The following is a description of a gene set: from publication Shinohara H, Behar M, Inoue K, Hiroshima M, Yasuda T, Nagashima T, Kimura S, Sanjo H, Maeda S, Yumoto N, Ki S, Akira S, Sako Y, Hoffmann A, Kurosaki T, Okada-Hatakeyama M (PMID 24833394) Genes down-regulated in B lymphocytes: wildtype versus MAP3K7. species: Homo sapiens Human Gene Set: GSE41176_WT_VS_TAK1_KO_UNSTIM_BCELL_DN The activation signaling of transcription factor nuclear factor-kB (NF-kB) plays central role for immune system. One of key kinase mediating this pathway is TAK1 in adaptive and innate immunity. However, role of TAK1 in B cell receptor signaling is still unclear. To know effects of TAK1-deletion on the gene expression induced by anti-IgM, we performed the time course analysis in comparison of wild type with TAK1-deleted splenic B cells., and this is the list of marker genes: TNS4, SPATA6L, SELP, CFD, HIGD1B, GGT7, TSLP, SPINK4, SLC6A5, ZNF563, MYL3, ADH4, SPOCK1, SAP18, CYP2U1, ARHGAP33, ADGRG3, PPARGC1A, ACKR1, ZCCHC18, TNFRSF19, CLEC4F, TRPM3, JADE2, TNFRSF9, KLHL11, CHCT1, MARF1, ABLIM2, COL9A1, KCTD2, COLEC11, CES5A, ADAM32, ANKRD63 (NCBI Gene Id 100131244), MUC13, NOG, GRIK2 (glutamate ionotropic receptor kainate type subunit 2), CNR1, PLEKHG5 (pleckstrin homology and RhoGEF domain containing G5), SLC38A5, KRT32, DDR1, CRYAA, CCDC25, ANGPTL7, TMEM74, KRTAP21-1, KXD1, CLK1, PDE3A, C22orf23, ATP7B, PRDM16, C16orf95, PEBP1, CGN, MIA, HTR1F, AICDA, CCDC73, OR10J5, THG1L, IL1R1, SOX3, DCAF12L1, PDP2, RBMXL2, ZFC3H1, CEND1, GANC, TTC23, MSX1, GPR3, DNAI2, NIPAL2, MAPK13, PSMB11, GRIK3, RGS12, WIF1, LHCGR, BTN1A1, MFAP1, FLVCR2, RRH, TINAG, SLC26A1 (NCBI Gene Id 10861), NSL1, ZNF239, OTOS, RPL35, FREY1, ADM2, CYP17A1, TMEM213, PLA2G2F, PGR, TNPO3, LYPD2, FAM181A, GP2, SLC22A6, TBX6, CHRNE, SLITRK4, TAS2R1, MACROD2, RERG, EPS15L1, USP49, CORT, C4orf19, H2BC13, PDZK1, C2orf72, GOLT1A, MYMK, PARVA, C5orf47 (NCBI Gene Id 133491), MED12L, PIP, MZB1, COL4A4, KLHL10, HAO1, TENM1, KL (NCBI Gene Id 9365), CHRNB1 (NCBI Gene Id 1140), TIE1, AQP5, CACNA1G (NCBI Gene Id 8913), HLA-DRA (NCBI Gene Id 7930), ATP10B, TUT1, DUS2, MISP, HLA-A, SLC1A2, CELA2A, GLP1R, CES1, DNALI1, SLC35F3, ITIH1, DYNC2H1, SLA2, LRRC20, CLPS, FOXA3, CELSR2, KCNJ16, TMEM121B, EMC1, TOGARAM2, GNE, SVOP, HOXC8, TMOD2, URI1, GP6, SYNE4, PCDHB7, LMNTD2, ATP13A4, DPPA5, GJB5, MAL, APOB, RBM11, NPAS1, PCDH20, ALK, SLC1A1, CCDC172, LRRIQ4, PCDHB16, SYT12, ELMOD3, HOXD8, LHB, CUX2, MROH3P, PSAPL1, TMIE, KIF2B, KIAA1549, CRPPA, SLC6A16, ARHGEF28, APBA2, JAG2 (NCBI Gene Id 3714), MYL6B, SYNE2, NEUROD4 (NCBI Gene Id 58158), TXNIP, SCN4B, CCDC102A, PROM2